The following is a description of a gene set: species: Mus musculus Mouse Gene Set: REACTOME_G2_M_DNA_DAMAGE_CHECKPOINT G2/M DNA damage checkpoint, and this is the list of marker genes: H2bc9, H4c3, Chek2, Blm, Rmi1, H4c1, Rfc2, Brip1, Topbp1, Pias4, Trp53bp1, Rad9a, Nbn, Cdc25c, Ccnb1, H2bc24, Rnf8, Nsd2 (NCBI Gene Id 77281), H2bc14, Rpa1, H2bc22, Abraxas1, H2bc15, H2bc21, H2bc13, Babam2, Rpa3, Rnf168 (NCBI Gene Id 70238), Rmi2, Rfc4, Wee1, H2bc12, H2bc8, Rad17, H4c2, Mdc1 (NCBI Gene Id 240087), Top3a, Ywhah, Chek1, H4c12, Mre11a, Rad50, Ywhaq, H4c11, Rfc3, H4c14, Ywhae, H4c18, Kat5, Rhno1, Rpa2, Trp53, Uimc1, Cdk1, Rbbp8, H2bc3, Ywhag, Babam1, H4c6 (NCBI Gene Id 319157), Brca1, Ube2v2, Atm, Atrip, Hus1, Ccna1, H4c9, H2bc1, Ywhaz, Wrn, H2bc23, Ube2n, Dna2, H3f4 (H3.4 histone, cluster member), H4c16, Brcc3, H2bc26, H4c4, H2ax, Rad1, Rad9b, Ccna2, H4c17, H2bc4, Sfn, H2bc6, Rfc5, Herc2, Ywhab, Exo1, H4c8, H2bc7, H2bc11, Bard1